The following is a description of a gene set: Human Gene Set: WP_CANONICAL_NFKB_PATHWAY studied in species Homo sapiens Canonical NF-kB pathway, and this is the list of marker genes: NFKB1, RELA, IKBKB, CHUK, REL, NFKBIA, IKBKG, NFKBIE